Given this list of marker genes CSPG5, DCN, NCAN, CSPG4, BGN (NCBI Gene Id 633), VCAN, BCAN, CHST3, here is a description of the gene set: species: Homo sapiens Defective CHST3 causes SEDCJD Human Gene Set: REACTOME_DEFECTIVE_CHST3_CAUSES_SEDCJD